Given this list of marker genes PABPN1L, PABPC5, PAN3, PABPC4L, DDX1, HNRNPDL, KHDRBS1, PABPN1, ZC3H14, PABPC1, RBMS3, HNRNPU, PABPC3, KHDRBS2, PABPC1L2A, RBMS1, PABPC4, PABPC1L2B, EIF4A3, TIA1, LARP4, PABPC1L, RBMS2, DDX3X, ELAVL4, PPIE, here is a description of the gene set: Human Gene Set: GOMF_POLY_A_BINDING studied in species Homo sapiens Binding to a sequence of adenylyl residues in an RNA molecule, such as the poly(A) tail, a sequence of adenylyl residues at the 3' end of eukaryotic mRNA.